The following is a description of a gene set: Genes predicted to be targets of miRBase v22 microRNA hsa-miR-486-3p in miRDB v6.0 with MirTarget v4 prediction scores > 80 (high confidence targets). studied in species Homo sapiens from publication Chen Y, Wang X (PMID 31504780) Human Gene Set: MIR486_3P, and this is the list of marker genes: NCKAP5L, IL2RB (interleukin 2 receptor subunit beta), CDC20B, DAB2IP, TRABD2B, PDE2A, ADARB1, ZC3H12A, SLC6A11, VOPP1, CCDC97, SEPTIN3, TMEM132E, ALDH3B2, CIDEC, NKD1, NACC2, FXYD6, SRCIN1, OTOF, NPTX1, PLPP5, DMBX1, LARGE2, FOXP4, AP1B1, TBC1D22B, IRF2BPL, NAA60, CNIH2, C19orf25, TTYH3, PAK6, E2F1, DOT1L, CRTC1, RTL5, RIMS4, ADGRL1, PRX, HEMK1, FBXW4, TRPV5, CAPN6, ARID1B, AATK, DVL3, TTBK1, ZSWIM3, KDELR1, ATXN7L3, MARK2, ABHD10, EPHB2, LIAT1, TMEM234, RPRM, MKNK2, CNTNAP1, LMCD1, RAPGEF1, MRPS5, C10orf105, SUV39H1, ASB14, RNF41, S100A10, RAPGEFL1, PLPPR2, SH3KBP1, NECTIN1, NSD1, PLCB1, SRC, TUBB, KCNAB2, ZSCAN22, CYB5RL, PLD3, SDC3, ADAM19, MIB2, CALCOCO1, NDOR1, FANCC, RNF145, ZNF512B, ITGB2, CD79A, MOB3B, ADH6, DLL4, GDI1, KMT2D, PACS2, PHF8, MEP1A, ARK2C, POU2F2, SF3A1, IGSF5, CACNA2D2, NFIC, MTMR12, IFITM5, DBNDD1, SAP30BP, PHAF1, BCL2, ORAI2, DNMBP, TANC2, CHST1, UTP25, TRAF3, BMPR2, AGO1, PLXNA4, ATF3, FLOT2, SCN2B, PLEK, H6PD, DIRAS1, SZRD1, WNT5B, MCM5, WNT4, SCRIB, PPARD, HRH3, CD209, GRM4, IMPDH1, MTCL2, CSRNP1, TYMSOS, CLDN19, DIS3 (NCBI Gene Id 22894), SAXO1, SOX10 (NCBI Gene Id 8223), SPOCK2, WASF2, EEIG1, CALN1, MICALL1, PEX26, YY1AP1, TRIOBP, TK2, CLCF1, PLEKHO2, ZDHHC8, DNHD1, CNP, TTC7B, SBK1, FBXO41, KLF12, DTX3, ELFN2, SLC9A8, MAP1LC3A, PGAP3, GATAD2B, ZNF215, HES7, SPIB, BRD9